Given this list of marker genes MYT1L, MAGEL2, MT-CO3, TTC8, DYNC1I2, POLD1, SEC24C, MT-ND6, OPHN1, TRIO, METTL5, BMPR1A, GALT, SDCCAG8, SRPX2 (NCBI Gene Id 27286), CTCF, GNB5, MLXIPL, ZMIZ1, PCNT, MKRN3, SLC13A5, TAF1, BBS5, MT-TQ, CIC, TUBB2B, SECISBP2, RIC1, FERRY3, FKBP6, KMT2A, KAT8, PCDH19 (NCBI Gene Id 89774), ALKBH8, SLC9A7, MT-CO2, GTF2IRD1, PAH, AUH, MT-ND4, SLITRK1, SPG7 (NCBI Gene Id 87549), CLTC (NCBI Gene Id 9511), NLGN1, TREX1, RREB1, CHD2 (NCBI Gene Id 283680), PWAR1, ANKRD11, ATP10A, MID1, FBXO11, YY1, GLI2, MKS1, ANAPC1, GRIA4, SRRM2, NECAP1, KMT2B, GABBR1, MAN2B1, EEF1A2, MT-ND1, DHTKD1, CDH11, PRKD1, EIF4A2, WDPCP, WAC, GABRB2, VPS13C, ARID2, DYRK1A, PARS2, RNU4-2, ATM, NIPBL, ZMYM3, MED12L, CDK19, DNAJC30, ARL6, SNORD115-1, SNRPN, PSMB1 (proteasome 20S subunit beta 1), CACNA2D1, PNKP, HIRA, ARPC4, NFIB, GLRX5, DNAJC6, SBDS, SOBP, CNKSR2 (NCBI Gene Id 22866), MAP1B, PAK3, GATA4, JARID2, FOXP1, LIMK1, CHD8, VPS13A, SMC3, MED13, IDS, NODAL, NEXMIF, ATP9A, KDM4B (NCBI Gene Id 23030), STEEP1, MAPK1, SYNE1, MUTYH, PPP2CA, NF1, TSC2, DEPDC5, SPTAN1, PTCHD1, CDKN2B, CHRNB2, CACNA1C, SNCA, ZBTB20, CREBBP, CEP290, SRCAP, ATP13A2, RAI1, TRAPPC14, CSGALNACT1, ELN, TNPO2, JMJD1C, TIAM1, HNRNPC, CDK8, GABRA1, ASL, FGF8, NKAP (NCBI Gene Id 79576), GNAQ, DISP1, GABRG2, SMPD1, FOCAD, CRH, KIF11, TGIF1, IFNG, GAS1, PRNP, SCN2A, DMPK (DM1 protein kinase), COMT, CLIP2, IFT74, BBS2, CRKL, PUS7, SIM1, TBX1, PCGF2, CHRNA4, SHH, AHCY, PTCH1, EMC10, CYP27A1, PLA2G6, SLC1A2, TUBG1, MRPL39, TWNK, TMEM163, NKX2-1, METTL27, UFD1, CHD5, MEN1, FZR1, CHEK2, CDH2, HEPACAM, PDZD8, LRRK2, STX1A, GNE, CHD7, ASPM, BBS4, FLII, MT-TF, UBE3A, SNORD116-1, DRD4, IFT27, RPS20, FANCD2, TET3, SIN3B, ASCC3, AARS1, SLC6A19, BBS1, BUD23, HDAC8 (histone deacetylase 8), YWHAG, BBS12, FGFR1, HLA-DRB1, TRAK1, GNB1, FOXH1, AP2M1, PODXL, SETD5, CABP4, NDP, WWOX, EHMT1, CDKN1A, CHD3 (NCBI Gene Id 1107), DLG3, TSHB, SATB1, PTEN, NBN, DYM, TAF6, HNRNPH2, UBAP2L, GALC, SMARCA2, NFIA, SCN3A, PPM1D, CELF2, KCNC2, DALRD3, FGD1, SLC38A3, TANC2, CAMTA1, OTC, WBP11, GRIN2A, TBL2, ADNP, DNM1, AP3B2, HNRNPR, NIPA2, PRR12, CACNA1A, AASS, UPF3B, HDAC4, UBA5, CDON, ADH5, NPHP1, AUTS2, BAP1, HNRNPK, DCDC2, SLC25A36, EFL1, SPEN, TNIK, ABCD1, CASP2, CYFIP2, ODC1, TLK2, CBL, KCNA4, CRIPTO, FOXP2, DPH2 (NCBI Gene Id 1802), VPS37D, USP7, SYNJ1 (synaptojanin 1), GABBR2 (NCBI Gene Id 9568), KCNB1, POLA1, SHMT2, HERC2, CDKN1B, HDC, BBIP1, BCORL1, BBS9, ZFX, SOX5, KMT5B, FGFR3, CC2D1A, CDC42BPB, SYNGAP1, SEMA3E, SCAPER, PMS2, MT-TH, ATP1A3, TGFBR2, MSH6 (mutS homolog 6), FLI1, BCKDK, CFAP418, GRIN2D, ZDHHC9, SCLT1, KRAS, HTRA2, SPRED1, NUS1, PDGFRB (NCBI Gene Id 5159), MT-CO1, TUBA1A, IGF1 (insulin like growth factor 1), HLA-DQB1, RFX7, SPTBN1, EPCAM, CDKN1C, MADD, DLL1, PTRHD1, PSAP, NAT8L, SRPK3, CHRNA2, THRB, OCA2 (NCBI Gene Id 4948), COQ5, IVD, TBL1X, SPG11, TMCO1, SLC7A6OS, TNFSF4, CTSH, ATP6V1A, BCR, ZMYM2, KANSL1, SH3KBP1, PMS1, NR2F1, TUBB3, STAG2, UBE4A, PACS2, SUCLG1, MBD5, RFC2, BBS7, ALDH4A1, IQSEC2, YME1L1, MT-TS2, GRIA1, MSH2, SCN1A, APC2, STIL, SATB2, BAZ1B, CORO1A, TMEM270, PRKAR1B, NSUN2, HOXA2, MT-TW, EIF4H, PIK3CA, GRIK2, GABRA2, RSRC1 (arginine and serine rich coiled-coil 1), TPH2 (tryptophan hydroxylase 2), PLCH1 (phospholipase C eta 1), CACNA1B, SH2B1, TRIM32, ARVCF, FBXO28, SLC6A8, GLUD1, TBX2, PINK1, GABRB3, SETBP1 (SET binding protein 1), KCNN2, CAPRIN1, KDM3B, MKKS (MKKS centrosomal shuttling protein), STS, IQSEC1, OCRL, PRKCG, HSPG2, PWRN1, DNAJC21, BBS10, SIX3, LGI3, NAA60, DPH1, FMR1, NCF1, CHRNA7, DNAJC12, BRD4, NBEA, KPNA3, PANK2, GP1BB, SOX6, FOXG1, KCNA2, IKBKG, POGZ, NSD1, SUPT16H, SHOC2, SETD1A, PPP1R21, LIG4, CEP19, GABRA5, JRK, IGF2, TFE3, RAD21, DHCR7, ATP1A2 (ATPase Na+/K+ transporting subunit alpha 2), MOG, NAA15, ATP6V0A1, CRBN, LHCGR, KCNH5, NOP56, FGF12, PIDD1, PLAG1, FLG, KAT5, SMC1A, CARS1, P2RY11, KIF14, GTF2IRD2, PARK7, PURA, HCN1, NTRK1, MED12, CNTNAP2, SLC2A1, MT-TL1, DHDDS, SZT2, SEMA4A, AGO1, TIMM8A, PRKN, CDKN2C, MLH1 (NCBI Gene Id 4292), H4C5, SMC5, MAB21L1, GTF2I, DEAF1, ZNF292, RERE, FANCL, ARSA, PRMT7, AGO2, TSC1, SLF2, LMAN2L, EIF2AK1, UCHL1, NIPA1, ADGRL1, DRD5, MCTP2, CSNK2A1, MT-ND5, ANKRD17, NSUN6, ADA2, ERF, PPP1R12A, SCN8A, CACNA1H, KCNT1, SCN9A (sodium voltage-gated channel alpha subunit 9), BRCA2, ACTL6B, ZIC2, NTRK2, EBF3, PIEZO2, TKT, PHIP, IFT172, TBC1D23, TMEM67, POLG, SCN1B, DDB1, HCRT, NPAP1, SIN3A, EP300, PHF21A, LZTFL1, TNRC6B, POLE, PPP3CA, TAOK1, HMGA2, ZNF365, SLC6A1, here is a description of the gene set: studied in species Homo sapiens Reduced attention regulation An abnormality in one's ability to control their attention towards a specific subject or task can include difficulties in changing or maintaining attention. Human Gene Set: HP_REDUCED_ATTENTION_REGULATION